The following is a description of a gene set: studied in species Homo sapiens from publication Jaeger J, Koczan D, Thiesen HJ, Ibrahim SM, Gross G, Spang R, Kunz M (PMID 17289871) Human Gene Set: JAEGER_METASTASIS_UP Genes up-regulated in metastases from malignant melanoma compared to the primary tumors. PURPOSE: To better understand the molecular mechanisms of malignant melanoma progression and metastasis, gene expression profiling was done of primary melanomas and melanoma metastases. EXPERIMENTAL DESIGN: Tumor cell-specific gene expression in 19 primary melanomas and 22 melanoma metastases was analyzed using oligonucleotide microarrays after laser-capture microdissection of melanoma cells. Statistical analysis was done by random permutation analysis and support vector machines. Microarray data were further validated by immunohistochemistry and immunoblotting. RESULTS: Overall, genes were identified that showed significant differential expression between primary melanomas and melanoma metastases (false discovery rate<or=0.05). Significantly overrepresented gene ontology categories in the list of genes were cell cycle regulation, mitosis, cell communication, and cell adhesion. Overall, genes showed up-regulation in metastases. These included Cdc6, Cdk1, septin 6, mitosin, kinesin family member 2C, osteopontin, and fibronectin. Down-regulated genes included E-cadherin, fibroblast growth factor binding protein, and desmocollin 1 and desmocollin 3, stratifin/14-3-3sigma, and the chemokine CCL27. Using support vector machine analysis of gene expression data, a performance of >85% correct classifications for primary melanomas and metastases was reached. Further analysis showed that subtypes of primary melanomas displayed characteristic gene expression patterns, as do thin tumors (<or=1.0 mm Breslow thickness) compared with intermediate and thick tumors (>2.0 mm Breslow thickness). CONCLUSIONS: Taken together, this large-scale gene expression study of malignant melanoma identified molecular signatures related to metastasis, melanoma subtypes, and tumor thickness. These findings not only provide deeper insights into the pathogenesis of melanoma progression but may also guide future research on innovative treatments., and this is the list of marker genes: RRM2, TUBB2B (tubulin beta 2B class IIb), NCAPG, TACC3, TBC1D1, STC1, PAPSS2, AURKA, CSAG3, PLOD2, NNT, MAGEA12, SMC4, EPS8, DDAH1, SPP1, NCAM1, GPI, HLTF, MET, THBS4, GINS4, MAGEA2, NCBP2, DTL, FN1, SCHIP1, NUDT9, CENPF, MERTK, SLC16A3, SNAP25, FCGR1A, SULF1, ENPP1, BGN, MME, CDC6, UCHL1, SEPTIN6 (NCBI Gene Id 23157), KIF2C, ADAM12, CKS2, IGHM, MAGEA3, H2AZ2